Given this list of marker genes Tent4a (NCBI Gene Id 210106), Syncrip, Paip1, Igf2bp1, Csde1, Pabpc1, Tent4b (NCBI Gene Id 70570), Ybx1, Hnrnpd, Hnrnpu, Dhx9, Tob1, here is a description of the gene set: studied in species Mus musculus Mouse Gene Set: GOBP_NEGATIVE_REGULATION_OF_NUCLEAR_TRANSCRIBED_MRNA_CATABOLIC_PROCESS_DEADENYLATION_DEPENDENT_DECAY Any process that stops, prevents or reduces the frequency, rate or extent of nuclear-transcribed mRNA catabolic process, deadenylation-dependent decay.